The following is a description of a gene set: species: Homo sapiens Congenital muscular torticollis A congenital form of torticollis resulting from shortening of the sternocleidomastoid muscle and leading to a limited range of motion in both rotation and lateral bending. Human Gene Set: HP_CONGENITAL_MUSCULAR_TORTICOLLIS, and this is the list of marker genes: MYT1L, MEOX1, SYNGAP1, GDF3, COL12A1, PPP2R5D, COL6A1, GDF6